The following is a description of a gene set: Mouse Gene Set: REACTOME_SYNTHESIS_OF_DIPHTHAMIDE_EEF2 species: Mus musculus Synthesis of diphthamide-EEF2, and this is the list of marker genes: Eef2, Dnajc24 (NCBI Gene Id 99349), Dph6, Dph1, Dph3, Dph2, Dph5